The following is a description of a gene set: studied in species Mus musculus Binding to a major histocompatibility complex class II molecule; a set of molecules displayed on cell surfaces that are responsible for lymphocyte recognition and antigen presentation. Mouse Gene Set: GOMF_MHC_CLASS_II_PROTEIN_BINDING, and this is the list of marker genes: Cd81, Cd4, Cd74, Fcrl6, Marchf8, Col2a1 (NCBI Gene Id 12824), Lag3